The following is a description of a gene set: Adducted thumb species: Homo sapiens Human Gene Set: HP_ADDUCTED_THUMB In the resting position, the tip of the thumb is on, or near, the palm, close to the base of the fourth or fifth finger., and this is the list of marker genes: ELN (elastin), LIFR, CLIP2, NALCN, GTF2I, NDE1, FBN1, VPS37D, MYH3, GNB1, GTF2IRD2, BICD2, TNNT3, AP4M1, DPH2, COL6A3, FKBP6, ERCC1, FILIP1, TPRKB, PIGY, EP300, ADGRG6, ANKLE2, STX1A, EIF4H, NCF1, SLC9A6, MED25, TAPT1, RTL1, GTF2IRD1, ALDH18A1, RBM8A, MYBPC1, LAGE3, MEG3 (NCBI Gene Id 55384), OSGEP, YRDC, FBN2, GON7, COL6A1, MSL3, BUD23, ECEL1, SMPD4, FBLN5 (NCBI Gene Id 11268), PCGF2, KLHL40, KATNB1, SYNE1, NEK9, TGDS, CRLF1, PHGDH, TNNI2, CHST14, RNU4-2, NEB, GPKOW, METTL27, DLK1, NUP107, COL12A1 (NCBI Gene Id 1304), KCNH1, LIMK1, TDO2, NUP133, TP53RK, ALG13, TMEM270, BLTP1, SLC35B2, WDR4, RFT1, CREBBP, KLHL41, LMOD3, BAZ1B, B3GALT6, MYL11, TPM2, ZEB2, RFC2, CRPPA, ATAD1, DNAJC30, CHST11, COG7, COL6A2, ALG3, EXOSC9, EPB41L1, WDR73, SHMT2, ACTA1, DSE, STUB1, TBL2 (NCBI Gene Id 27203), TOR1A, RELN, L1CAM